Given this list of marker genes Cul3, Rb1, Anapc11, Mad2l1bp, Anapc7, Anapc5, Ska1, Cdc20, Ska3, Ube2c, Mapk15, Cenpe, Cdc23, Cdc16, Prap1, Mad1l1, Nsmce2, here is a description of the gene set: studied in species Mus musculus Mouse Gene Set: GOBP_POSITIVE_REGULATION_OF_METAPHASE_ANAPHASE_TRANSITION_OF_CELL_CYCLE Any process that activates or increases the frequency, rate or extent of metaphase/anaphase transition of cell cycle.